The following is a description of a gene set: species: Homo sapiens Enables the transfer of L-serine from one side of a membrane to the other. L-serine is the L-enantiomer of 2-amino-3-hydroxypropanoic acid. Human Gene Set: GOMF_L_SERINE_TRANSMEMBRANE_TRANSPORTER_ACTIVITY, and this is the list of marker genes: SFXN3, SERINC3, SLC1A4, SLC38A2, SFXN1, SLC38A5, SERINC5, SLC7A10, SLC1A5